The following is a description of a gene set: studied in species Homo sapiens Synthesis of dolichyl-phosphate Human Gene Set: REACTOME_SYNTHESIS_OF_DOLICHYL_PHOSPHATE, and this is the list of marker genes: MVD, DOLK, NUS1, DHRSX, DOLPP1, DHDDS, SRD5A3